The following is a description of a gene set: Catalysis of an oxidation-reduction (redox) reaction in which hydrogen or electrons are transferred from each of two donors, and molecular oxygen is reduced to two molecules of water. studied in species Mus musculus Mouse Gene Set: GOMF_OXIDOREDUCTASE_ACTIVITY_ACTING_ON_PAIRED_DONORS_WITH_OXIDATION_OF_A_PAIR_OF_DONORS_RESULTING_IN_THE_REDUCTION_OF_MOLECULAR_OXYGEN_TO_TWO_MOLECULES_OF_WATER, and this is the list of marker genes: Scd4, Scd1, Cyb5a, Degs2, Fads1, Fads6, Fads2, Scd3, Degs1, Scd2, Peds1, Fads2b, Sc5d, Fads3, Degs1l (NCBI Gene Id 619326)